The following is a description of a gene set: Human Gene Set: chr2p11 species: Homo sapiens, and this is the list of marker genes: IGKV1D-17, PTCD3, IGKV2D-36, IGKV2D-14, IGKV2D-24, KCMF1 (potassium channel modulatory factor 1), RN7SL126P, MIR4771-1, ABCD1P5, IGKV2-24, GPR160P1, RNU6-1007P, IGKV3-7, RETSAT (retinol saturase), RN7SL113P, SMYD1, WBP1P1, VAMP5, IGKV1D-13, IGKV2D-10, IGKV1OR2-1, IGKV3D-25, IGKC, IGKV1D-16, IGKV2-18, TMEM150A, IGKJ1, ENSG00000204745, IGKV4-1, FABP1, ENSG00000225420 (NCBI Gene Id 101928371), TRABD2A, SNORD94, EIF2AK3-DT, IGKV1-39, ENSG00000309324, SPMIP9, RNU2-63P, IGKV2D-19, IGKV2-29, IGKV3-20, PGBD4P5, FUNDC2P2, IGKV1-35, ANAPC1P2, PLGLB2 (NCBI Gene Id 5342), KMT2CP4, IGKV1D-8, IGKV3D-31, IGKV3-34, IGKV1-27, IGKV3-15, IGKV3D-15, MIR4779, IGKV2D-38, CHMP3-AS1, SUCLG1, IGKJ5, IGKV3-11, IGKV1-16 (NCBI Gene Id 28938), KMT5AP2, CD8A, SH2D6 (SH2 domain containing 6), CHEK2P3, IGKV2D-29, LINC01955, EIF2AK3, RN7SKP83, IGKV1-33, IGKV2D-28, SNRPEP11, C2orf68, FOXI3, IGKV2D-26, IGKV1-13, TGOLN2, LINC01964, MAT2A, RPL37P10, IGKV6D-41, GGT8P, IGKV1-5, IGKV1-12, IGKV3D-11, ST6GALNAC2P1, NKAIN1P2, ANAPC1P5, KMT2CP5, DBF4P3, USP39, PEBP1P2, ANAPC1P4, IGKV1D-37, CAPG, RNU6-1312P, MTATP8P2, IGKV1D-42, TCF7L1, RNU1-38P, POLR1A, VAMP8, GGCX, IGKV2-14, IGKV1D-27, CYTOR, LSP1P5, MIR4436A, MALLP2, IGKV6D-21, IGKV7-3, RNF103, IGKV3D-34 (NCBI Gene Id 28871), IGKV2-10, LINC01943, CRLF3P3, RPSAP22, IGSF3P2, IGKV1-8 (immunoglobulin kappa variable 1-8), RNU6-640P (NCBI Gene Id 106479850), IGKV3-25, IGKV2-19, MIR4435-1, IGKJ4, KRCC1, PLGLB1, ST3GAL5-AS1, NDUFB4P7 (NADH:ubiquinone oxidoreductase subunit B4 pseudogene 7), IGKV2-30, THNSL2, IGKV3OR2-268, IGKV1-17, RPS2P17, IGKV2D-30, RNU6-1168P, RPIA, IGKJ2, LSM3P3, IGKV6-21, CD8B, TMSB10, PAFAH1B1P1, IGKJ3, IGKV1OR2-2, ATOH8, IGKV1D-22, IGKV3D-20 (NCBI Gene Id 642113), IGKV1-32, IGKV3D-7, RMND5A, ENSG00000202537, RNF181, ANAPC1P1, SLC9B1P2, CHMP3, IMMT, ACTR3BP2, PARTICL, DUXAP1 (double homeobox A pseudogene 1), ANAPC1P3, WBP1P2, IGKV1-9 (NCBI Gene Id 28941), RN7SL251P, ENSG00000290846, IGKV2-4, IGKV2-23, IGKV1D-33, IGKV1-37, DRD5P1, IGKV5-2, DNAH6, MIR6071, LINC01809, TCF7L1-IT1, RPS14P5, RGPD2, MRPL35, RPL38P6, IGKV2-38, IGKV2-36 (NCBI Gene Id 28918), MRPL45P1, KDM3A, IGKV2D-23, REEP1, LSP1P4, PABPC1P6, ELMOD3, IGKV1-22, IGKV1D-12, IGKV1D-39, IGKV2-26, RPL12P18, IGKV2D-18, IGKV2-28, CENPNP1, ST3GAL5, RNA5SP100, IGKV3-31, SFTPB, MIR4780, IGKV2-40, RGPD1, IGKV1D-43, IGKV1OR2-118 (NCBI Gene Id 3526), GNLY, IGKV1-6, IGKV1D-32, NDUFB4P5, NCAL1, LDHAP7, RNU6-674P, RNF103-CHMP3, ANKRD36BP2, IGKV1D-35, IGKV2D-40